Given this list of marker genes Trak1, Rhot2, Mfn1, Myo19, Rhot1, Mfn2, Trak2, here is a description of the gene set: studied in species Mus musculus Miro GTPase Cycle Mouse Gene Set: REACTOME_MIRO_GTPASE_CYCLE